The following is a description of a gene set: studied in species Homo sapiens Any process that results in a change in state or activity of a cell (in terms of movement, secretion, enzyme production, gene expression, etc.) as a result of an interferon-beta stimulus. Interferon-beta is a type I interferon. Human Gene Set: GOBP_CELLULAR_RESPONSE_TO_INTERFERON_BETA, and this is the list of marker genes: MNDA (NCBI Gene Id 4332), UBE2K, IFITM2, PYHIN1, HTRA2, TRIM6, HCN1, STAT1, AIM2, TLR3, TREX1, PYDC5, IFNAR1, CDC34, CAMK2A, IRGM, CAPN2, NDUFA13, IFNAR2, IFNB1, IFI16, UBE2G2, IRF1, ACOD1, STING1, CALM1, DDX41 (DEAD-box helicase 41, NCBI Gene Id 96647), PNPT1, OAS1